The following is a description of a gene set: Mouse Gene Set: chrXE2 studied in species Mus musculus, and this is the list of marker genes: Gm14930, H2ab3, Pcdh11x, Gm4993, Gm5394, Gm22590